Given this list of marker genes NFKB1, CYGB, PPID, INO80, SDHD, COMT, ZFP36L1, DDIT4, NDNF, CABP4, SMAD3, PLAC8, DNAJB6, LCN2, OPN1MW2, MAP3K4, WNT11, MTOR, KCNQ1, MYB, AQP3, BGLAP, GUCY1B1, BNIP1, PKD1L1, KCNA1, TSC22D4, MIR146A, DDHD2, PARTICL, VASN, CRNN, ATXN1, FOXO1, LTA, CLPB (NCBI Gene Id 81570), STAT1, TRPC6, MKKS, NOL3, PLAT, SERPINE2, CHRNA9 (NCBI Gene Id 55584), GNGT2, FOXB1, PPARA, NPFFR2, CACNB4, NUCKS1, PINK1, ANGPT4, HSF1, CDS1, NOP53, RYR2, FBXO4, GNAT3, PLOD1, BRCA2, LRRC8A, ENSG00000274276, MMP9, SLC52A3, HPCA, OPN1MW, MAP3K2, GNGT1 (G protein subunit gamma transducin 1), LZIC, PKD1L3, FANCD2, NR2F6, ITGB3, HABP4, TRPV4, PRKDC, KRAS, CCAR2, EYS (NCBI Gene Id 8414), PIANP, SLC2A4, TLR8, RELA, TRPV2, CPEB2, HIF3A, CRY2, EPHA4, HDAC2, FBXL21P, PIEZO1, TLK2, CXCR4, NLRP1, GRM6, APAF1 (apoptotic peptidase activating factor 1), LARGE1, GCLC, CNN2, TBL2, ABCA4, MMP14, ATP2B4, STK11, MAPK10, MT-ND5, SUN1, STC1, PRKCE, SIRT1, ATP1A2, MAPK13, CRTC1, DCT, STRBP, GATA4, TSC22D3, DCANP1, CPEB4, OPRD1, KCNC1, MSH2, MCOLN1, CLCN2, HDAC3, CLK2, THRA, WRN, MIR762 (NCBI Gene Id 100313837), RYR1, NFATC4, ROM1, ENG, PPP1CA, BABAM1, ATP1A1, PPARG, MICA, LYN, CITED2, TRPM1, NLK, OXT, PRIMPOL, POLD3, CRY1, ADAM8, NABP2, ACTR5, DRD3, BRCC3, TTR, HSPD1, USP1, DAXX, BAD, ELK1, RAD9A, KCNJ8, CLDN3, IHH, DCLRE1C, ZRANB3, PKD2, TAFA2, DDB2, UCN, SOD3 (NCBI Gene Id 6649), CCDC115, SUV39H1, VPS13A, ZNF516, EEF1D, NIPBL, KIT, IER5, PRKACA, FEN1, ADSS2, CBFA2T3, PPARD, HMOX1, FGF16, LRRN4, EEF2K, NOS2, MIR21, TMEM87A, P2RX3, RP1, SCAP, SCN2B, DMD, EGLN1, INTS3, FIS1, TFAM, GHR, HUS1, CASP8AP2, TNFRSF1A, ERCC4, RHO (NCBI Gene Id 6010), LXN, ADORA1, LOXL2, BCL3, ID2, CHCHD2, ICOSLG, CRB1, CALB1, CAB39, GPLD1, HSBP1L1, FRMPD1, VEGFD (NCBI Gene Id 2277), DCUN1D3, MAP2K7, EIF2AK3, ABRAXAS1, PYCARD, ZEB2, DPM1, LIMD1, ATP6AP1, RTN4, MIR20A, ENDOG, HDAC6 (histone deacetylase 6), DYNLRB1, TIFAB, BDKRB2, CYB5R4, YAP1, RCVRN, WTIP, HYAL2 (NCBI Gene Id 8692), CBL, NR2E3, SLC7A5, SCEL, MAPK14, SDE2, GPR52, TM9SF4, TP53, GNAQ, SIRT4, OPN1LW, ADAM2, PKD1, NMU, SPIDR (scaffold protein involved in DNA repair), ETV1, BMP7, RAC1, TNFRSF10B (TNF receptor superfamily member 10b), ANKRD1, GPR31, WDR47, TRIAP1, NONO, SAG, GRB2, CPT1A, WNK1, MAP1B, UBQLN1, IVL, CYP2R1, RAD1, FGF2, PTCH1, PRKCD, FAM162A, TCIM (NCBI Gene Id 56892), RETN, ATP8A2, VEGFA, ARNT, CDKN1A, PMAIP1, NLRP3, STAT3, CIDEA, USP19 (ubiquitin specific peptidase 19), FADD, ERCC3, SLC9A1, TMEM150C (NCBI Gene Id 649616), MAP3K7, EPHB1, CREBBP, RAD54L (RAD54 like), REEP6, MPO, RBP4, EGR1, MT3, SST, NOC2L, MECP2, DDX3X, RBM4B, CHRNA7, FOXP2, ANKRD23, CYBB, RHBDD1, HIGD1A, ATG7, UCP1, TXNIP, UNC119, TANK (TRAF family member associated NFKB activator), MSH6, PLN, MICB (NCBI Gene Id 91956), KARS1, SDF4, FECH, HSD11B2, CHRNA4, PRKCA, FIGNL1, DTL, TMC2, PSEN2, MC1R, CA9, HRAS, CTSS, HSPA1A, CTNS (cystinosin, lysosomal cystine transporter), XRCC2, TIGAR, EP300, CCNB1, DNAJB1, CHI3L1, TICRR, RGR, SWI5, NPHP1, DRD1, NPY, VEGFC, ABCA7, ALAS1, PTPRQ, NPS, GRK1, NFE2L2, GPX1, MRNIP, EGLN2, IGFBP2, XRCC5, HILPDA, PTGER4 (NCBI Gene Id 5734), NPPC, MAP4K3, MPL, AKT2, KCNJ3, HYAL1, NPPA, FGFR2, FABP1, ANGPT2, ANG, CHRNA10, UCN3, TTC36, LRIT1, KAT5, USP53, LIG4 (DNA ligase 4), H2AC25, POLD1, PNPLA2, PDK3, SLC12A6, RPTOR, IRF1, SLC8A3, AIFM1, RHOB, IL12A, UCP3, KDM1A, ADSS1, CASP7, BCL10, SOD2 (NCBI Gene Id 79099), INTS7, MME, GAP43, TSC1, NMT1, NRXN2, SMPD2, MAPK8, GNB5, DUSP1, TFRC, RRH, SUMO1, TTN, PTPN1, EIF2B4, CCND2, MAP1LC3A, ALKBH5, DNMT3A, KCNK9, AKR1B1, FXYD2, ITGB1 (integrin subunit beta 1), SCNN1G, SCARA3, PRICKLE1, CCNA2, TMEM135, CASR, RDH13, PER3, RAD51, PKN1, AQP1, PTPN11, ATM, PER1, CHRNB2, RFWD3, MGARP, GPI, RORA, PIRT (phosphoinositide interacting regulator of transient receptor potential channels), CD24, MT-CYB, IRAK1, FOSB, TNFRSF8, PKLR, MALAT1, ATF2, ERCC2, BDKRB1, USF1, MAG, BHLHE40, MIR106B, ASCL2, PAK1, METRNL, DPP4, SCN9A, STAC, ZFAND1, MYC, TLR4, DNAJB4, PAXIP1 (PAX interacting protein 1), RO60, CLOCK, PTEN, FMN2, RBBP7, GUCY1A2, FZD4, GDF5, TAC1, PDE6B, NOG, TAC4, TREM2 (triggering receptor expressed on myeloid cells 2), NET1, CSRP3, TRPV3, MAP2K4, FBXL3, ERCC6, DNAJA1, XRCC4 (NCBI Gene Id 7518), RAD21, YWHAE, CCDC66, CAV3, SLC12A5, MLST8, MAPK3, SHANK3, TNF, PHF24 (NCBI Gene Id 23349), SFRP2, ADIPOQ, STUB1 (STIP1 homology and U-box containing protein 1), CUL4A (NCBI Gene Id 8451), SLC24A4, HSP90AA2P, MMP2, MYOG, FKBPL, THBS1, CACNA1F, SOST, NSMF, SMPD1, PARP2, TERC, HTRA2, SLC1A1, PKD1L2, CRYAB, LEP, CXCL12, GUCY1A1, HSP90B1, GRIA1, KCNK3, ECT2, ABCB1, HSPB6, NDRG4, GPR88, CHEK1 (checkpoint kinase 1), P4HB, HSPA1B, RCSD1, TRPC3, HMGCS2, PSPH, UIMC1, ABCC9, BBS10, RGS14, LETM1, FOSL2, KRT5 (NCBI Gene Id 3852), F7, SOD1, CD38, STX1A, HK2, RNF170, EI24, GPSM2, GJA10, CHP1, SIRT2 (sirtuin 2), LIPA, SCN2A, B4GALT2, PCLAF, HYOU1, TNFRSF10A, BLM, PIAS1, TNC, DISC1 (NCBI Gene Id 80138), SNAI2, PDLIM1, KIAA0319L, EDN1, NHEJ1, APPL2, ATF4, AIPL1, PML, GPR68 (NCBI Gene Id 8111), EIF2B3 (eukaryotic translation initiation factor 2B subunit gamma), RBM4, NGFR, TMBIM6, AQP5, EDNRA, ITGB6, TGFB2, CASP9, SLC1A3, BNIP2, RPL26, AK4, TLR5, SLC24A1, H2AX, NTSR1, NOS3, PRDM12 (PR/SET domain 12), CCL7, BBC3, GRM1, NDRG1, IKBIP, ABHD12, USP2, EYA3, SERPINB6, TMEM161A, OPN1SW, MIR448, PDZD7, GUCA1A, SOX2, CDC25A, STK39, MT-ND4, PRPH2, MT-ATP6, CLCA1, TFEC, CAMKMT, SLC27A1, KCND2, SCN7A, EYA1, EPAS1, ERCC5, SLC25A23, DNAJA4, SFRP1, ITGAM, SLC6A4, SRF, EIF2S1, ATOH7, GRK4, GUCY2F, IGF1 (NCBI Gene Id 3479), MT-ND1, PRKAA1, MDK, ERCC1, DNAJA2, GJB6, NDUFS2, NEUROG1, SIRT6, LRRC8E, TMEM109, HSP90AB2P, GHRL, GSK3B, ANO3, KCNMA1, DRGX, HNRNPD, MIR17, RPAIN, IL12B, HSP90AA1, PAPPA2, CUL4B, RELB, ADRB3, GSN, HPN, BAK1, KMT2A, BNIP3, SOX9, TRPM8, ALAS2, PLEKHN1, PIN1 (NCBI Gene Id 5300), UCK2, PIK3CB, STRA6, SMAD4, LGMN, N4BP1, AURKB, HP1BP3, PLAU, BMP2, MSTN, RUVBL2, COPS3, GPR151, APP, NSMCE3, KCNK1, SUV39H2, PDPK1, PLK3, NOTCH1, LRP11, NOX1, CBS, HSP90AB3P, PIK3R1, NFE2L1, HVCN1, NFAT5, PER2, BRAF, BEST1, GATA6, NINJ1, ITPR1, MAP3K14, DDAH1, HSPA2, PIERCE1, SCN1A, JUND, B3GAT1, USP28, RGCC, SLC26A5, HTR2A, THBD, SLC1A2, POLK, NR4A2, RNF168, ATAT1, MARVELD3, DNAJC7, SYNGAP1, ASIC3, AVPR1A, SCN11A, CASQ1, SPRTN, CERS1, CETN1, GPR4, P2RX5, UVSSA, RHNO1, FBXW7 (NCBI Gene Id 55294), ATP6V1A, USP15, CXCL10, TPR, ADRB1, TRPV1, PDE2A, GRIN1 (NCBI Gene Id 2902), CACNA2D4, HRH1 (histamine receptor H1), CLCN6, TIPIN, TGFBR3, ASCL1, AANAT, ANGPTL4, LRRC8D, TRIM32, RGS9BP, TIMELESS, EIF2B2, CASP3, CASP2, TNKS1BP1, CCND1, PTGIS, PLOD2, ADAM15, PCNA, MMP1, CTNNB1, SLC2A1, LRIT3, SERPINF1, FANCG, TYR, BECN1, TGFB3, ASIC2, ADRB2, BRAT1 (NCBI Gene Id 221927), MMP3, TACR2, METTL3, MEN1, PPM1D, CPEB1, MTA1, GBA1, CD40, DRD2, GRIN2A, WNK3, DNAJA3 (DnaJ heat shock protein family (Hsp40) member A3), RAB11B, MIR145, FBP1, ERO1A, BNIP3L, XPA, SCNN1A, ERCC8, GUCY2D, ASIC1, TMEM120A, BRD1, UBE4B, TH, TOPBP1, TLR7, CAPN2, PPP1R1B, EIF2B5, SLC7A11, NABP1 (NCBI Gene Id 64859), MIR214, PDE8B, CFLAR, ATP6V0A2, HSP90AB4P, MEIS2, KIAA0319, CHORDC1, CRIP1, CYP1A1, XRRA1, KCNC2, ATP6V1G1, YBX3, KCNA5 (potassium voltage-gated channel subfamily A member 5), PTPRK, XRCC6, IL13, RAD54B, SAXO1, AKAP12, PDE1B, VCP, TACR1, AKAP9, HIPK2, DAG1 (dystroglycan 1), KRT14, VGF (VGF nerve growth factor inducible), SEMA5B, MIR223, HYAL3, MDM2 (MDM2 proto-oncogene), MTCH2, E2F1, OPN3, UCP2, INSRR, SCNN1B, OXSR1, LCN10, TMC1, EIF2B1, NETO1, KCNJ11, CNGB1, RBX1, IFT20, SLC12A2, REST, TCAP, TXNRD2, ACER1, IL1A, BIRC2, POLA1, ACAA2, SERPINB13, KDM4D, NFKBIA, ADSL, TRIM63, GRK7, AGRP, EPO, MAP3K20 (mitogen-activated protein kinase kinase kinase 20), CCL11, P2RX2, NGB, RCAN1, HSPB2, EGLN3, DNAJC3, TANC1, IFI16, PKDREJ (polycystin family receptor for egg jelly), EFHD1 (EF-hand domain family member D1), MAP7, OTOP1, TSC22D2, SLC24A2, ZBTB1, BAX, POLB, CDH2, MICU1, XPC, BARD1, SLITRK6, STC2, PLEC, TRPA1, PTGS2, RAD9B, SLC29A1 (solute carrier family 29 member 1 (Augustine blood group)), IL1B, HIKESHI, RIC8A, ADA, CIAO3, COL6A2, PARP1, MLC1, JUN, POLH, BRSK1, ANO1, COL1A1 (collagen type I alpha 1 chain), LHFPL5, NDP, SLC8A1, MIR210, POSTN, GRIK2, SMC1A, BCL2L1, AQP2, FOS, S100B, CRADD, INHBA, NOX3, ST20, PGF, TIMP1, MAP2K1, BABAM2, NF1, COP1, FUNDC1, TXN, TULP1, NEDD4, PDC (phosducin), TNFRSF11A, MFAP4, WHRN, UMOD, COL18A1, PIEZO2, TOP1, MTCO2P12, ACOT11, CREB1, UBE2A, RNF34, OPN1MW3, GLRX2, TP53BP1, PITPNM1, COL3A1, HSPG2, AEN, CASP5, FGF1, HSBP1, HSP90AB1, MDM4, PDE6C, P2RY1, ACADVL, SLC4A10 (solute carrier family 4 member 10), TP53I13, TSPYL5, CNTNAP2, JUP, HIGD1C, PCSK1N, MAPKAPK2, GAB1, F11R (F11 receptor), TWIST1, RAG1, ALDH18A1 (NCBI Gene Id 9193), SLC2A8, RWDD3, KMO, MBD2, RPE65, SCNN1D, FZD3, HMOX2, CYBA, GOT1, MIR140, TEK, RAD51AP1, NPEPPS, PDK1, CDH8, VEGFB, ST8SIA1, AKT1, HOXA1, VCAM1, OPN5, PPL, HSPB1, PKD2L2, YY1, RRM1, KCNK18, EGFR, PALM, NOS1, COPS9, RGS9, MYO15A, DIO3, ALAD, ATP1B1, GNA11, NRXN1, LMNA, OGG1, PIK3CA, MT-ND3, GPR65, TMEM199, TP53INP1, AGTRAP (NCBI Gene Id 57085), DNAJC2 (DnaJ heat shock protein family (Hsp40) member C2), HPCAL4, CAV1, CASP8 (caspase 8), PLIN1, EXT1, APOBEC1, ELANE, COL11A1, COL6A3, TLR3, ABCC8, PSIP1, BCL2, BACE1, MAP3K1 (mitogen-activated protein kinase kinase kinase 1), STRC, DDB1, SCX, SIPA1, COMMD1, WDR83, GNAT2, HTT, TRPM2, PBK, VHL, SCARA5, PPP1CC, ARSB, MYD88, ARHGEF2, GTF2H2, ADGRV1, UBE2B, BMP6, SLU7, LPAR1, MT-ND2, MIR34A, ABAT, CLN3, COL6A1, SLC38A2, DBH, FOXO3, CAT, TREX1, INIP, EIF2AK4, GUCA1B, MT-CO2, CPT1B, NTRK1, ERRFI1, AGER, TNFSF14, ARNT2, CDKN2D, TSPO, KCNK2, CAPN3, MB, HMGN1, ITGA2, TAF1, KCNQ3, BMF, MT-CO1, GNAT1, MAPT, SIK1, P2RX7, PENK, HSPA6, TGFB1, PRAP1, HIF1A, ELOVL4, CDK5, PJVK, BRCA1, CALR, NMT2, LTBR, PNKP, ATR, ENO1, PDCD6, LONP1, DRAM1, CEP250, PTPRC, KCNK4, GTF2H5, OPN4, PCP2, KCNJ2, ATXN3, PICK1, ZMPSTE24 (zinc metallopeptidase STE24), CRYAA, GADD45A (NCBI Gene Id 1647), MYOCD, FAS, MYOD1, LRRC8C, PLEKHB1, GATA3, NPHP4, ATP6V0D1, RNF8, LIF, PTK2, PGK1, PTN, NPM1, ROCK2, REV1, CIRBP, ACADM, MMP24, MTHFR, RAB3A, GMPR, SLC25A27, CHEK2, CASP1, MYLK, ADO, DEAF1, RAF1, RAB11FIP5, ITPR2, BAG3 (NCBI Gene Id 9531), HMGCR, SCRN3, NKX3-1, PPP1CB, SLC11A2, ADAM17, PKD2L1, NEUROD2, GUCA1ANB-GUCA1A, DDR2, TUBA1A, ABCG5 (ATP binding cassette subfamily G member 5), TERT, SLC4A11, FYN, CLCN7, DHX36 (NCBI Gene Id 96337), PECAM1, MAPK11, BTG2, AJUBA, here is a description of the gene set: species: Homo sapiens Any process that results in a change in state or activity of a cell or an organism (in terms of movement, secretion, enzyme production, gene expression, etc.) as a result of an abiotic (not derived from living organisms) stimulus. Human Gene Set: GOBP_RESPONSE_TO_ABIOTIC_STIMULUS